Given this list of marker genes CFLAR, SDK2, ERCC4, CDT1, ZNF367, LHFPL2, APLN, LMAN2L, CLVS1, TESK1, RAB7A, ZNF530, ATXN3, MACROD2, ELF4, MMP20, FBXO42, EPHA7, RAP2C, CHST10, RBM14, ZNF426, LSS, ZNF594, BPTF, CREBRF, SH2D4B, ZNF74, LRP5L, PIAS2 (protein inhibitor of activated STAT 2), HS1BP3, CLEC5A, PARD3B, FLI1, ACSL1, BRWD3, LRRC28, BDH1, BICD2, SFRP4, FMO5, IGF2BP2, IRF2, PCSK7, MED14, ENAH, ZNF844, FCAMR, MRRF, PLPP3, YWHAH-AS1, GPX2, CD81, POGLUT1, ZNF763, UBR2, APOLD1, SNAP47, NR2E1, RAB9B, ARPP21, RMDN3 (NCBI Gene Id 55177), TM2D3, BZW1, AGAP1, TNFRSF21 (TNF receptor superfamily member 21), GOLPH3L, EPSTI1, PRKAA1, SCO1, SLC2A13, HADHB, AMMECR1L, ZNF268, FIS1, SSH2, HDLBP, WDR82, ELMO2, FBLN5, DCAF5, ZNF135, GABRG1, B4GALT5, PLXNA2, GOLPH3, DOCK5, NEGR1, PGRMC2, ZNF24, GAB2, SMIM21, TAF4, ANK2, PSKH1, NREP, here is a description of the gene set: from publication Chen Y, Wang X (PMID 31504780) Human Gene Set: MIR4493 species: Homo sapiens Genes predicted to be targets of miRBase v22 microRNA hsa-miR-4493 in miRDB v6.0 with MirTarget v4 prediction scores > 80 (high confidence targets).